The following is a description of a gene set: Genes up-regulated in wildtype bone marrow-derived macrophages: control versus IL4 and rosiglitazone. Conditional macrophage-specific PPARg knockout mice were generated on C57Bl/6 background by breeding PPARg fl/- (one allele is floxed, the other is null) and lysozyme Cre transgenic mice. PPARg and IL-4 signaling was analyzed on bone marrow-derived macrophages. Bone marrow of 3 mice per group was isolated and differentiated to macrophages with M-CSF (20 ng/ml). 20 ng/ml IL-4 was used to induce alternative macrophage activation and 1 uM Rosiglitazone (RSG) was used to activate PPARg. From each mouse 4 samples were generated: 1. M-CSF, 2. M-CSF+RSG, 3. IL-4 and 4. IL-4+RSG. All compounds were added throughout the whole differentiation process, and fresh media was added every other day. Control cells were treated with vehicle (DMSO:ethanol). After 10 days, RNA was isolated and gene expression profiles were analyzed using Mouse Genome 430 2.0 microarrays from Affymetrix. from publication Szanto A, Balint BL, Nagy ZS, Barta E, Dezso B, Pap A, Szeles L, Poliska S, Oros M, Evans RM, Barak Y, Schwabe J, Nagy L (PMID 21093321) species: Homo sapiens Human Gene Set: GSE25123_CTRL_VS_IL4_AND_ROSIGLITAZONE_STIM_MACROPHAGE_UP, and this is the list of marker genes: E2F4, KLRD1, SH3BP1, DNAJB2 (NCBI Gene Id 3300), ZBED3 (zinc finger BED-type containing 3), RAB5C, ZDHHC9, BPNT1, CNR2, RBMS2, LSM2, UTP15, MYO1G, EMC4 (NCBI Gene Id 51234), ELF4, PPP1R18, CTR9, NAA40, ARHGDIB, TP53RK, ATF7, SUPT4H1 (NCBI Gene Id 6827), SS18, RAB3GAP2, VANGL2, CECR2, LMNB1, NLRC5, ADIPOR1, G6PC2 (NCBI Gene Id 57818), LENG8, PSME3, COPS7B, ELF2, CD8A, FRG1, ZNF169, PRCP, SIGMAR1, RNF41, DENND5A, IFNGR2, TLE1, SLC37A3, ZNF146, ANXA5, MYL10, CASS4, PEAK1, SLC9A9, TMEM38A (NCBI Gene Id 79041), IRAK3, BICRAL, ATP13A2, RBM45, DGKQ, LEPROTL1, EVL, PPP1R35, UNKL, ADORA2A, PNISR (PNN interacting serine and arginine rich protein), BMF, STK25, BCL9, TMEM248, SUOX, B4GALT4, RMC1, NOTCH3, PLAA, CPT1A, ERC1, SPINT2, SMAD3, SNX5, RHOA, DDOST, EIF1B, TMEM106C, CTXN1 (cortexin 1), PFN1, PSAP, SH3PXD2A, YWHAB (tyrosine 3-monooxygenase/tryptophan 5-monooxygenase activation protein beta), JUNB, HLA-C, GFM2, PPP3CA, FBL, CD37, CAB39, SLC25A51, ASH2L, ST6GAL1, NPM3, ZNF652, SETD1B, MS4A1, B4GALNT1, VAPB, LYRM4, HM13, COP1, QRICH1, CXCR4, IL12RB1, EIF2AK3, AMPD1, NDRG2, UGCG, RNF213, CLBA1, ZFP36L2, RAB12, SNX18, USP18, PEX5, CHRNB1, DNMT3A, LYSMD2, PPP4R3A, TMEM81, IFT80, NMNAT1, GPATCH2L, CDK13, TSC22D3, TTC5, ZNF3, NARF, WDR18, PRKAB2, PTPN9 (NCBI Gene Id 5780), NCSTN (NCBI Gene Id 57297), GNA11, DNAJB11 (DnaJ heat shock protein family (Hsp40) member B11, NCBI Gene Id 51726), GRB2, ALDH18A1, CCDC71, HNRNPH1, GABPB1, SLC7A6OS, ZDHHC5, B2M, GFOD2, LEF1, CBX8, RRAD, MAPK6 (NCBI Gene Id 5597), ARPC4, RAB19, PCGF5, HEXIM1, EPS8L1, LAMC1, PBX2, ASS1, RNF167, PRCC, AP2B1, CSDE1, SLC10A2, KLHL42, PIK3IP1, STK35, PDZD11, TNFSF10, GPR171, ARL4C, FLT3LG, KANSL1, RCC2, RTP4, SLC35C1 (NCBI Gene Id 55343, solute carrier family 35 member C1), ATXN7L3 (ataxin 7 like 3), HIPK1, IRF4, TSPYL4, EIF4A1, AGRN, PPP4C, CCDC43, IFI27L2, ITFG2, SERPINA7 (NCBI Gene Id 6906), H2BC3, NF1, TP53, PRRT1, IRF9, CCR7, ZC3H14, RTN4, HMGB1, RASSF2 (NCBI Gene Id 9770), STARD5, SPRING1, NDRG3, EPS15L1